Given this list of marker genes HLA-DRB1, TEK, B2M, P4HA2, STK11, IL12B, CALR, F5, HLA-B, MEFV, MLX, PTPN22, COL3A1, JAK2, here is a description of the gene set: Gastrointestinal infarctions studied in species Homo sapiens Human Gene Set: HP_GASTROINTESTINAL_INFARCTIONS